Given this list of marker genes TMT1A, MAOB, TESC, POF1B, EMB, CD36, MPZL2, DSC2, AOX3P, GSTO1, AQP4, RPL17, GALNT13, FUT9, ARSK, FABP4, here is a description of the gene set: Epithelial organs, including the lung, are known to possess regenerative abilities through activation of endogenous stem cell populations, but the molecular pathways regulating stem cell expansion and regeneration are not well understood. Here we show that Gata6 regulates the temporal appearance and number of bronchioalveolar stem cells (BASCs) in the lung, its absence in Gata6-null lung epithelium leading to the precocious appearance of BASCs and concurrent loss in epithelial differentiation. This expansion of BASCs was the result of a pronounced increase in canonical Wnt signaling in lung epithelium upon loss of Gata6. Expression of the noncanonical Wnt receptor Fzd2 was downregulated in Gata6 mutants and increased Fzd2 or decreased beta-catenin expression rescued, in part, the lung epithelial defects in Gata6 mutants. During lung epithelial regeneration, canonical Wnt signaling was activated in the niche containing BASCs and forced activation of Wnt signaling led to a large increase in BASC numbers. Moreover, Gata6 was required for proper lung epithelial regeneration, and postnatal loss of Gata6 led to increased BASC expansion and decreased differentiation. Together, these data demonstrate that Gata6-regulated Wnt signaling controls the balance between progenitor expansion and epithelial differentiation required for both lung development and regeneration. studied in species Mus musculus Human Gene Set: ZHANG_GATA6_TARGETS_UP Genes up-regulated after cre-lox knockout of GATA6 in airway epithelium. from publication Zhang Y, Goss AM, Cohen ED, Kadzik R, Lepore JJ, Muthukumaraswamy K, Yang J, DeMayo FJ, Whitsett JA, Parmacek MS, Morrisey EE (PMID 18536717)